Given this list of marker genes SOX10, CDH19, ZC3H12A, CTNND1, JUP, CTNNB1, CTNNA1, here is a description of the gene set: Regulation of CDH19 Expression and Function species: Homo sapiens Human Gene Set: REACTOME_REGULATION_OF_CDH19_EXPRESSION_AND_FUNCTION